Given this list of marker genes ZDHHC4, ZDHHC14, ZDHHC6, ZDHHC17, YKT6, ZDHHC15, ZDHHC23, DLST, ZDHHC3, ZDHHC16, ZDHHC9, ZDHHC20, MCAT, FASN, ZDHHC22, ZDHHC11, ZDHHC24, ZDHHC18, ZDHHC5, ZDHHC11B, ZDHHC1, ZDHHC2, ZDHHC21, ZDHHC12, ZDHHC19, DLAT, ZDHHC7 (NCBI Gene Id 55625), GLUL, ZDHHC8, ZDHHC13, here is a description of the gene set: studied in species Homo sapiens Catalysis of the transfer of an acyl group to a sulfur atom on the acceptor molecule. Human Gene Set: GOMF_S_ACYLTRANSFERASE_ACTIVITY